Given this list of marker genes Ank1, Gmps, Clec12a, Crxos, Trib1, Irf9, Tmem167, Kif2c (NCBI Gene Id 73804), Cd200r3, Krtap8-1, Ago1, Glb1l2, Fstl5, H2al3, Angptl4, Nup98, Gja1, Rpap2, Rhob, Cyp2g1, Itga9, Aim2, Zfp229, Msl2, Nsd1, Adgrb3, G6pdx, Fkbp1a, Cdh10, Syt11, Ifnlr1, H2-M10.3, Acad8, Clec7a, Ptchd4, Klf12, Trim2, Zfp446, Osbpl1a, H2-M10.5, Lamp5, Smg6, Trio, Gpr22, Nadk, Pde4a (NCBI Gene Id 52001), Cfb, Cnot9, Plin5, Kcnh1, Acbd5, Krt6b, Eif5a2, Tmem106b (transmembrane protein 106B), Rad51d, here is a description of the gene set: species: Mus musculus Mouse Gene Set: MIR_672_5P Genes predicted to be targets of miRBase v22 microRNA mmu_miR_672_5p in miRDB v6.0 with MirTarget v4 prediction scores > 80 (high confidence targets). from publication Chen Y, Wang X (PMID 31504780)